The following is a description of a gene set: The chemical reactions and pathways involving any amino acid that is incorporated into protein naturally by ribosomal translation of mRNA, and that has a specific codon for translation from mRNA to protein. Human Gene Set: GOBP_PROTEINOGENIC_AMINO_ACID_METABOLIC_PROCESS species: Homo sapiens, and this is the list of marker genes: GLUD2, BHMT, ALDH4A1, HMGCLL1, GCLC, IDO2, TTC36, PRODH, TH, ADSS2, GSTZ1, AADAT, CBS (NCBI Gene Id 875), SMS, OCA2 (NCBI Gene Id 4948), GCLM, ENOPH1, GPT2, SERINC5, CARNMT1, MECP2, MCCC2, GOT2, PYCR1, HAL, SRR, HNMT, DDO, NOXRED1, PSPH, SERINC3, GLYATL1, PRODH2, HMGCL, ARG1, SLC45A2, ARHGAP11B, TDO2, FTCD, DGLUCY, ASRGL1, BCKDK, DAO, SDSL, AASS, ENSG00000274276, UCP2, FPGS, CLN3, GLS, AZIN2, CSAD, PLOD3, GOT1, NOS3, TYR, ATCAY, BCAT2, GPT, GAD1, KMO, NOS1, CDO1, ADI1, SLC38A8, DLST, IDO1, ASNSD1, BHMT2, HGD, NR1H4, SIRT4, THAP4, KYNU, MTHFS, HDC, ASL, ASS1, AUH, NAT8L, MTHFD1, CPS1, AGMAT, ASPG, ALDH5A1, NADSYN1, RIMKLB, ALDH18A1, PAH, MTR, PIPOX, IL4I1, GLYAT, AMDHD1, RIDA (NCBI Gene Id 137671), NOS2, GCAT, MAT1A, CAD, CARNS1, AMT, ODC1 (NCBI Gene Id 4953), DCT, LGSN, SLC7A11, GCSH, SDS, MTRR, GLUD1, SHMT1, GNMT, UROC1, GLS2, MIR21, ATP7A, TAT, GGT1, MSRA, APIP, ASPA, NAGS, ATF4, PYCR3, GAD2, GLDC, GCDH, ARG2, OAT, IVD, PYCR2, DDAH1, GOT1L1, PLOD2, HPD, AZIN1, ATP2B4, FAH, NDP, MCCC1 (methylcrotonyl-CoA carboxylase subunit 1), MTHFR, ASNS, SHMT2, HAO1, ADHFE1, GLUL (glutamate-ammonia ligase), PHGDH, HAAO, QDPR, BAAT, RIMKLA, AGXT2, AFMID, ACMSD, BLOC1S6, IYD, OTC, ADSS1, PFAS, PCBD1, NIT2, PSAT1, GLYATL1B, AGXT